Given this list of marker genes Ptgr3, Ngrn, Gpr88, Pik3r1, Myb, Gdi1, Them4, Elk1, Eif5, Spata6l, Bcat1, Grhl2, Zfp788, Gpd2, Tfip11, Hoxa9, Per1 (NCBI Gene Id 18626), Fbxw11, Fdft1, Lrrc19, Slitrk2, Eif4g3, Smim3, Rreb1, Scn2b, Myh1, Inpp5a, Pign, Cyld, Coq3, Ust, Mlycd, Pomk, Adipor2, Gabrg2, Rnf34, Cip2a, Prdm4, Osbpl6, Pappa, Gm11545, Nectin2, Dusp13a, Cbll1, Gripap1, Map3k3 (NCBI Gene Id 26406), Ppargc1a, Hs3st3b1, Plekhm3, Angel2, Shisa4, Chd2, Ssr3, Sp5 (NCBI Gene Id 64406), Manba, Kcnj15, Hif3a, Adamts17, Eml2, Prkar1a, Ptx3, Kcnip1, Amer1, Actr10, Fads6, Kitl, Tardbp, Rnf135, Igf1r, C2cd2l, Lhx2, Btla, Klhl24 (kelch-like 24), Mbd6, Frrs1l, Tspyl5, Ryk, Pdlim1, Elapor2, Rmi1, Ndc1, Ggnbp2, Nr1d2, Fbxo21, Atp6v1h, AW209491, Cmip, Crtac1, Tada1, Ephb2, Nat10, Cnga4, Nalcn, Mylk, Zfp235, Ikzf2, Fjx1, Lcor, Cpd, Gpr160, Trp53inp2, Rasef, Mgme1, Pom121, Lratd1, Tmem245, Fut9, Usp44, Slc13a5, Kif7, Capn8, Gpank1, Sp1, here is a description of the gene set: studied in species Mus musculus from publication Chen Y, Wang X (PMID 31504780) Genes predicted to be targets of miRBase v22 microRNA mmu_miR_5127 in miRDB v6.0 with MirTarget v4 prediction scores > 80 (high confidence targets). Mouse Gene Set: MIR_5127